Given this list of marker genes CD81, IL21, SLC39A10, CDKN1A, ATAD5, TLR9, TFRC, IL10, GPR183, MIF, RC3H1, BTK, IL5, TYROBP, NCKAP1L, FCRL3, CD320, BCL2, BST1, CD38, IL13, BCL6, PELI1, CD22, TLR4, CHRNB2, TNFSF13B, CD74, MNDA, MIR185, TNFSF13, CD300A, IL7, LYN, IL2 (NCBI Gene Id 3558), WNT3A, CDKN2A, ADA, MZB1, FCGR2B, TNFRSF4, TCF3, CARD11, PKN1, CD40, TNFRSF21, BMI1, IKZF3, CASP3, TICAM1, NFATC2, INPP5D, SASH3, TNFRSF13C, EPHB2, PTPRC, CTLA4, VAV3, TIRAP, AHR, IRS2, IL4, PAWR, MEF2C, CLCF1, PRLR, ATM, TNFRSF13B, here is a description of the gene set: Human Gene Set: GOBP_REGULATION_OF_B_CELL_PROLIFERATION species: Homo sapiens Any process that modulates the frequency, rate or extent of B cell proliferation.